The following is a description of a gene set: Human Gene Set: GGGGCCC_MIR296 studied in species Homo sapiens Genes having at least one occurence of the motif GGGGCCC in their 3' untranslated region. The motif represents putative target (that is, seed match) of human mature miRNA hsa-miR-296 (v7.1 miRBase)., and this is the list of marker genes: SMG7, TAOK3, SOX21, ZFP36L2, LRRC41, HOXD3, LARGE1, ADAMTSL1, CTIF, IQSEC2, PPM1N (NCBI Gene Id 147699), CNTFR, CCDC88B, FOXL2, UNC5A, PLPPR5, SYNGAP1, RETREG3, SLC30A3, SLC25A22, ACE, ELK1, WNT2, DBN1, GPX3, TRPM2, ZNF219, HIPK1, LYPLA2, ARAP1, DRD3 (dopamine receptor D3), PPFIA3, FOXP1, POU3F1 (POU class 3 homeobox 1), RTN2, EPN1, PPP2R5B, RNF44, VKORC1L1, SCRT1, GNB2, ATG2B, ARRB1, GPC2, SH3D21 (NCBI Gene Id 79729), SRF, MAP7D2, SOX11, SOX12, PARP6, SOX10, IPO11, AMMECR1L, CACNB1, ZC3H10, ACTR1A, CLIP3, ZNF740, GMPR, ZBTB4 (zinc finger and BTB domain containing 4), TRIM41, LRCH4, KCTD17, PRKACA, ONECUT2, FAM89B, NUMBL, PTPN5, PPAN, KREMEN2, NOG, SRRM3, CPLX2